Given this list of marker genes RTL3, SERPINB2, SEMA7A, ACSL5 (acyl-CoA synthetase long chain family member 5), RASGRP4, PPCDC, NUMA1, HOXC4, VEGFA, SCAF11, SARNP, NDN, LUC7L, MAS1L, FGF14, SHISA6, RELA, HLX, MAGED2, TSPAN7, TMEM145, RABGAP1L (NCBI Gene Id 9910), TSC22D1, EPC2, CACNG2, ZNF137P, CRIM1, SARS1, PLEKHS1 (pleckstrin homology domain containing S1), PTPN12, PIK3C2A, STK40, SOX4, CTNNBIP1, SCML1, LBX2-AS1, SSX2IP, NFX1, VNN3P, RBFOX1, C6orf15 (NCBI Gene Id 29113), UBE2E4P, GPLD1, FSIP2, BCL11B, SLC44A4, ARMCX4, RFX4, SEC14L3, MEIS1, GGNBP2, NEUROD1, STAG2, LRRTM1, HYPK, HSD11B1, NTRK1, ROR1, IRX6, BEND6, SEZ6, DMD, IL1RAPL2, GLRA3, ADRB2, CHAT, P2RY1, MAP4K4, OSMR, CHD6, SAT1, ZIC4, KCNMA1, MRPL12, GOT1, RTL9, LRTOMT (NCBI Gene Id 613203), SAV1, FGF12, DYNC1LI2, PTPRU, ASCL3, DDR2, HOXB7, POFUT1, C22orf31, TP63, STC2, ROBO4, TUBA1A, CCN2, RGS8, MBNL2, FKBP3, AHNAK, ABRAXAS2, GLRA2, CGNL1, FOXP1, NUDT3, SLC39A14, PLAG1, AMTN, H3-3B, FBXW7, SLC22A8 (solute carrier family 22 member 8), ZMAT4, LMO3, DLG2, PLA2G4A, UNG, ETF1, CELF3, RRM1, CHD2, OVOL1, MYL1, SLC12A1, PTAFR, FSTL1, RAB1A, ING3, ETV1, MITF (NCBI Gene Id 7487), GPX1, HDAC9, RHOQ, RAB6A, SLC24A4, PLCB2, IKZF4, DIS3L, BDNF, CEBPB, PRG4, HOXA3, ZFHX3, BCL2L13, NUP153, NR1D1 (NCBI Gene Id 9572), RORA, JAKMIP2 (janus kinase and microtubule interacting protein 2), TTC9C, RNF39, AP1S2, C12orf50, RARB, RLF, TNNC2, DCN, MAP2K6, ITPK1, BOC, APC, ERC1, ZIC1, MAP2K3, PLAGL2, MSL3, ACVR1, DENND4A, RNF38, PIK3R1, LTB, RPS19, CACNA2D3 (calcium voltage-gated channel auxiliary subunit alpha2delta 3), LIN54, DNAJB14, LRRTM3, NCKAP5, KLF5 (KLF transcription factor 5), USP2, RBM39, TGM3, NPTN (NCBI Gene Id 27020), ALDOA, TAFA1, NOSIP, FOXO3, OSBPL6, DLX1, ENTHD1, PRDX6, PDE4D, NFKBIA, LEMD2, SUPT4H1, GATA4, C18orf21, PRRG2, ATAD5, CREB5, WNT10B, CHST9 (carbohydrate sulfotransferase 9, NCBI Gene Id 83539), TSGA10, EHF, RAD23B, PHACTR4, PROX1, IL1RAPL1, PDGFRA, ZNF676, JMJD1C, CA3, JUN, PER1, RERE, here is a description of the gene set: Genes having at least one occurrence of the motif NGWVTKNKGYAAKNSAYA in the regions spanning 4 kb centered on their transcription starting sites. This matches the CEBPA transcription factor binding site V$CEBP_C (v7.4 TRANSFAC). species: Homo sapiens Human Gene Set: CEBP_C